The following is a description of a gene set: Th1 and Th2 cells arise from a common precursor cell in response to triggering through the TCR and cytokine receptors for IL-12 or IL-4. This leads to activation of complex signaling pathways, which are not known in detail. Disturbances in the balance between type 1 and type 2 responses can lead to certain immune-mediated diseases. Thus, it is important to understand how Th1 and Th2 cells are generated. To clarify the mechanisms as to how IL-12 and IL-4 induce Th1 and Th2 differentiation and how TGF-beta can inhibit this process, we have used oligonucleotide arrays to examine the early polarization of Th1 and Th2 cells in the presence and absence of TGF-beta after 0, 2, 6 and 48 hours of polarization. studied in species Homo sapiens from publication Lund R, Aittokallio T, Nevalainen O, Lahesmaa R (PMID 14607935) Genes down-regulated in CD4 T cells activated by anti-CD3 and anti-CD28: IL-12 (48h) versus untreated (48h). Human Gene Set: GSE2770_IL12_ACT_VS_ACT_CD4_TCELL_48H_DN, and this is the list of marker genes: NUF2, ICE2, AP1B1 (adaptor related protein complex 1 subunit beta 1), RNF41, GGT7, PPIE, KPNA4, CS, NCKIPSD, CROCC, FBXO10, CD79A, CCT2, PCLAF, CRYBG2, GALNT12, DHX37, EGR3, PCM1, FMR1, COPG2, CDK2, VPS33A, RFX7, POLR1B, KLHL14, SETX, NPM1, IPO5, RGS19, RPGR, CLUAP1, GMEB1, TMX4, HAUS2, CARMIL3, PKIB, RFX2, IGF2BP3, STIL, PRMT5, USB1, MTPN, DCAKD, TAF4, CDCA3, CNOT9, ORMDL1, TSN, MRGBP, PPP3CB, CHCHD10, PLEKHO2, FHIP1A, SMARCC1, NHERF4, ARMH3, FRMD5, ZNF395, EPOP, PARP3, SLC29A1, ADNP2, RPS6KA3, BRIP1, RIPK2, DFFA, SGSH, TUBGCP6, ULBP1, ST13, NDUFAF5 (NCBI Gene Id 79133, NADH:ubiquinone oxidoreductase complex assembly factor 5), POLR1F, VHL, RANBP17, FCHSD2, SIAH1, OR4C3, C18orf54, SS18, MDC1, MED11, RRAS2, KRAS, COPRS, ZNF48, KDM1A, RABEP1, ESCO2, DTYMK, PDIK1L, PHF2, ZCCHC2, C16orf87, BRD9, PRDM16, MAX, KNL1, RHEBL1, IL2RB, DIAPH2, CRTC2, LITAF, SAMD11, RETREG3, SPRING1, PIF1, FAU, POLR3B, SEC22C, PTEN, HIC1, CBX7, BATF, ZNF579, FLT3, CTSH, GMNN, DNAJC17 (DnaJ heat shock protein family (Hsp40) member C17), IRF5, TOP2B, DDX47, MGA, TMEM216, ITPR3, PCTP, MAPK11, VSNL1, CMTM3, RAPGEF1, SDE2, NFATC2IP, NAAA, NACC1, NSUN5, ZNF507, PPP1R21, TTC39B, SNRPD1, SRBD1, MIF, EHBP1L1, KCNS1, DMXL2, MTMR3, MUTYH, FASTKD3, NUP54, RGS12, TPK1 (NCBI Gene Id 27010), QSER1, MIDN, ATP10D, HNRNPA2B1, DUS2, KTN1, BRAT1, NAA50, MAP2, DYRK1A, ANAPC11, FUBP3, TTC21B, SLC4A8, OSGIN2, FHIP1B, PDHX, ADAMTS6, RBL1, MYCBP2 (MYC binding protein 2), GRB2, CEP250, CBX2, MSL3, ZBTB43, URB2, ZMIZ1, MTBP, TUSC3, MZT1, TBC1D10C, KCTD20, STAG1, PLCB3, CAB39L, LSM2, ITPA, SLC25A37, UNC119B, NEIL1, RPGRIP1, KIF22, IQCE, TRIM59, EZR, POGK, PVT1 (NCBI Gene Id 5820), CORO1A